Given this list of marker genes Chrnb2, Lpar1, Nav2, Nkx2-2, Rpl24, Kcnc2, Slc38a8, Kcna3, Ext1, Tmem126a, Pax2, Kcna1, Kcna2, Ndp, Slc25a46, Tcirg1, Kcnc1, Ephb1, Ephb2, Gli3, Atoh7, here is a description of the gene set: The process whose specific outcome is the progression of the optic nerve over time, from its formation to the mature structure. The sensory optic nerve originates from the bipolar cells of the retina and conducts visual information to the brainstem. The optic nerve exits the back of the eye in the orbit, enters the optic canal, and enters the central nervous system at the optic chiasm (crossing) where the nerve fibers become the optic tract just prior to entering the hindbrain. Mouse Gene Set: GOBP_OPTIC_NERVE_DEVELOPMENT species: Mus musculus